The following is a description of a gene set: Human Gene Set: GOBP_POSITIVE_REGULATION_OF_MAINTENANCE_OF_SISTER_CHROMATID_COHESION Any process that increases the extent to which the association between sister chromatids of a replicated chromosome is maintained. studied in species Homo sapiens, and this is the list of marker genes: MACROH2A1 (NCBI Gene Id 9555), BUB1, SMC5, NSMCE2, SLF1, SLF2